The following is a description of a gene set: species: Homo sapiens Human Gene Set: HP_OCULOMOTOR_APRAXIA Ocular motor apraxia is a deficiency in voluntary, horizontal, lateral, fast eye movements (saccades) with retention of slow pursuit movements. The inability to follow objects visually is often compensated by head movements. There may be decreased smooth pursuit, and cancelation of the vestibulo-ocular reflex. Oculomotor apraxia, and this is the list of marker genes: DLAT, TMEM237, SUFU, TMEM231, TCTN2, EXOSC3, SORL1, IFT74, SALL4, XRCC1, COG8, TOMM40 (translocase of outer mitochondrial membrane 40), SLC30A9, TCTN1, UFC1, PIGY, B9D1 (NCBI Gene Id 27077), PGAP3, HYLS1, CC2D2A, OFD1, TMEM216, FA2H, ABCA7, TUBA1A, KIAA0753, PSEN1, KIAA0586 (NCBI Gene Id 9786), CSPP1, ITPR1, PEX6, HECTD4, MAPT, TUBB3, PIBF1, APP, TUBB2B, PNPT1, CEP120, ZC4H2, TMEM107, TOGARAM1, PIGO, TCTN3, CACNA1A, AFG3L2, MAFB, APTX (aprataxin), H4C11, PEX2, TMEM67 (transmembrane protein 67), TMEM218, SETX, SLC1A3, CEP104, RPGRIP1L, BCR, ATXN2, GBA1, TREM2, TMEM138, PNKP, STUB1, IFT172, TYROBP, ATP1A2, ARL3, PEX10, PIGV, KATNIP, CHN1, ARMC9, KCNH1, PDE6D, SQSTM1 (sequestosome 1), TOE1, CEP41, ABCD1, PGAP2, GPAA1, INPP5E, RORA, AHI1, NGLY1, PMPCA, CPLANE1, DNM1L, MYT1L, NPHP1, BLTP1, MAPK1, TUBB4A, B9D2, MRE11 (MRE11 homolog, double strand break repair nuclease), PIGL, MAST1, PIGW, CRKL, NUP54, CEP290, TPP1, SPR, PIK3R5, GRID2, EBF3, ARL13B, MKS1, LAMA1, MYO9A, PSEN2, KDM1A, CBY1, ATP1A3, CACNA1G, CWF19L1, SOX3, BRAF